Given this list of marker genes Tgm4, Slc6a4, Ednrb, Oxt, P2ry1, Oxtr, Svs3a, Oprm1, Ar, P2rx1 (purinergic receptor P2X, ligand-gated ion channel, 1), Klk14, Abat, Avpr1a (arginine vasopressin receptor 1A), Ddo, Cnr1, Ada, Acvr2a, Tacr1, Vip, Drd4, P2ry2, Shh, Serpine2, here is a description of the gene set: The act of sexual union between male and female, involving the transfer of sperm. Mouse Gene Set: GOBP_COPULATION studied in species Mus musculus